The following is a description of a gene set: Mouse Gene Set: chr9C species: Mus musculus, and this is the list of marker genes: Dpp8, Fbxl22, Aagab, Gm39363, Gm19219, Mir190a, Gm23428, Lctl, Gm18541, Gm7802, Igdcc4, Gm22455, Pdcd7, Dennd4a, Pif1, Lactb, Gm16144, Slc24a1, Usp3 (ubiquitin specific peptidase 3), Ppp1r2-ps4, Ubap1l, Gm22145, Gm15511, Igdcc3, Anxa2, Zwilch, Mir7242, 1700055C04Rik, Herc1, Gm19299, Gm18587, Rasl12, BC050972, Aph1c, Oaz2, C2cd4a, Plekho2, Gm16759, Gm36033, Smad3, Snapc5, Ice2, Zfp609, Vps13c, Snx22, Aph1b, Snx1, Gm16218, Gm25995, Ankdd1a, Slc51b, Dis3l, Gm16073, Ints14, Tipin, Iqch, Dapk2 (NCBI Gene Id 13143), 2300009A05Rik, Map2k5, Gm22382, Smad6, Gm22657, Tpm1, Clpx, Mtfmt, Gm7787, Gm23344, 4930502A04Rik, Gm24347, Mir3109, Map2k1, Gm20745, Ciao2a, Trip4, Rpl4, Gm22571, Gm10646 (NCBI Gene Id 102632690), Rbpms2, Mir7241, Ppib, Tln2 (talin 2), Gm24289, Uchl4, Gm10647, Gm4978, Csnk1g1, Rab11a, Gm2553, Kbtbd13, Pclaf, Rab8b, Gm17875, Gm17749, Gm6257, Rora, Parp16, Cilp, Gm19987, M5C1000I18Rik, C2cd4b, Gm23248, Hacd3, Car12, Scarletltr, Megf11, Spg21, Rps27l